Given this list of marker genes ZNF569, ZNF382, ZNF383 (NCBI Gene Id 163087), ZNF461, ZNF875, ZNF790, ZNF420, ZNF570, ZNF781, ZNF585B, ZNF571, ZNF345, ZFP30, ZNF568, ZNF540, ZNF529, ZNF793, ZNF527, ZNF829, ZNF567, ZNF260 (zinc finger protein 260), ZNF585A, here is a description of the gene set: Genes within amplicon 19q13.1 identified in a copy number alterations study of 191 breast tumor samples. from publication Nikolsky Y, Sviridov E, Yao J, Dosymbekov D, Ustyansky V, Kaznacheev V, Dezso Z, Mulvey L, Macconaill LE, Winckler W, Serebryiskaya T, Nikolskaya T, Polyak K (PMID 19010930) A single cancer cell contains large numbers of genetic alterations that in combination create the malignant phenotype. However, whether amplified and mutated genes form functional and physical interaction networks that could explain the selection for cells with combined alterations is unknown. To investigate this issue, we characterized copy number alterations in 191 breast tumors using dense single nucleotide polymorphism arrays and identified genes with copy number gain organized into 30 amplicons. Amplicons were distributed unequally throughout the genome. Each amplicon had distinct enrichment pattern in pathways, networks, and molecular functions, but genes within individual amplicons did not form coherent functional units. Genes in amplicons included all major tumorigenic pathways and were highly enriched in breast cancer-causative genes. In contrast, genes with somatic mutations in breast cancer were distributed randomly over the genome, did not represent a functionally cohesive gene set, and were relatively less enriched in breast cancer marker genes. Mutated and gained genes did not show statistically significant overlap but were highly synergistic in populating key tumorigenic pathways including transforming growth factor beta, WNT, fibroblast growth factor, and PIP3 signaling. In general, mutated genes were more frequently upstream of gained genes in transcription regulation signaling than vice versa, suggesting that mutated genes are mainly regulators, whereas gained genes are mostly regulated. ESR1 was the major transcription factor regulating amplified but not mutated genes. Our results support the hypothesis that multiple genetic events, including copy number gains and somatic mutations, are necessary for establishing the malignant cell phenotype. Human Gene Set: NIKOLSKY_BREAST_CANCER_19Q13.1_AMPLICON species: Homo sapiens